Given this list of marker genes MBNL2, HOXB5, WAC, PPP4C, PKP4, EI24, PELI1, EFCAB14, FBXO28, SCYL2, SMC1A, PTER, PTP4A1, TRIM33, NMNAT2, SLC23A2, YTHDF3, MLEC, DCUN1D1, KRIT1, TEX12, EPB41L4B, SENP1, FNBP4, RLIM, TOB1, NF2, CSK, SSX2IP, TRHDE, XPO1, MSANTD2, GSE1, BLNK, SLC17A7, ZCCHC24, ERC2, C1orf21, SLAIN1, VPS26A, ITGA10, DAG1, KCTD12, ZNF281, JAK2, ZCCHC14, ZIC2, RANBP10, PRR7, FN1, ST3GAL5, CAPZA2, NPLOC4, CLEC5A, PSIP1, SPIN1, ARMC8, GNAI1, DCAF17, RNPS1, MDGA2, ZBTB2, PPM1E, LARP4, LENG8, TMED9, FRMD4A, TMEM163, SH3GLB1, IGF2BP3, PHF20L1, RELB, ALDH18A1, ARHGAP5, NUFIP2, CACNA1G, CLINT1, PTPN5, ZNF280D, CHST2, PLPPR1 (phospholipid phosphatase related 1), KDELR1, PALS1, PMEPA1, EPHB2, HDAC1, FIGNL2, PLAG1, NABP1, SP2, ARID5B, VCP, RALGAPB, TBL1XR1 (NCBI Gene Id 81612), CSDE1, KLHL13, EIF4A1, RAP1A, MOB3B (MOB kinase activator 3B), GABRB3, MBP, IPPK, RSRP1, SLC38A2, PPARGC1A, SOX9, ATP2B4, TRA2B, KHDRBS2, SEH1L, PPP3CA, PPP2R5C, KPNA4, HIF1A, VCPKMT, RAB11A, DHX58, SMNDC1 (survival motor neuron domain containing 1), FLRT2, SRSF5, KTI12, BPNT2, C9orf72, FOXE1, ALK, ADRA1A, HARS2, DNAJB6, PABPN1, FGFR2, SOX4 (SRY-box transcription factor 4), ARHGAP21, HOXA3, CAMK4, ING4, AP1G1, CCNJ, OPRK1, ZC3H6, SCUBE3, PHTF2, ISL1, MRFAP1, EN2, MAF, WDFY1, C2orf69, CAPN3, TNRC6A, GOPC, NAA30, UBE2G1, CBFB, MAFB, FBLN5, ZNF236, CLASP1, ARID4A, SAMD12, ARFGEF1, KPNA3 (NCBI Gene Id 3839), KCNIP2, BUB3, WDR44, CASP8, FKBP4, LSM14A, CSNK1E, SERTAD2, PITPNM2, SLC4A4, SURF4, NDFIP1, PDIK1L, DLG4, BRD2, PURB, IFFO1, ARF4, SH3PXD2A, CFL2, NAA40, PKNOX2, MYO5C, AMMECR1, UBAP1, ILRUN, MS4A2, RNGTT, IPO5, RLF, TMEM167B, SYT4, PAFAH1B1 (platelet activating factor acetylhydrolase 1b regulatory subunit 1), GRM3, DSCAML1, MYB, BAZ1A, RIC8B, CACNG4 (calcium voltage-gated channel auxiliary subunit gamma 4), CCER1, NAV1, PRUNE1, USP7, HACD2, ARFIP1, KLF5, GOLGA4, UBE3A, WTAP, TMEFF1, MTMR4, ORC2, ADAMDEC1, TARDBP, ELOVL5, FBXW7, TCEANC2, SETD3, ACTR2 (actin related protein 2), GRK3, ZFAND3 (NCBI Gene Id 60685), EEF1A1, MYCN, ELOVL2, here is a description of the gene set: Human Gene Set: TTTTGAG_MIR373 Genes having at least one occurence of the motif TTTTGAG in their 3' untranslated region. The motif represents putative target (that is, seed match) of human mature miRNA hsa-miR-373* (v7.1 miRBase). species: Homo sapiens